Given this list of marker genes RBPMS, UNK, RBM24, MIR485 (microRNA 485), MIR31, here is a description of the gene set: species: Homo sapiens Binding to an mRNA molecule coding sequence (CDS). Human Gene Set: GOMF_MRNA_CDS_BINDING